The following is a description of a gene set: The chemical reactions and pathways resulting in the formation of carbohydrates, any of a group of organic compounds based of the general formula Cx(H2O)y. studied in species Mus musculus Mouse Gene Set: GOBP_CARBOHYDRATE_BIOSYNTHETIC_PROCESS, and this is the list of marker genes: Gys2, Has2, Gpd1 (glycerol-3-phosphate dehydrogenase 1 (soluble)), Gpi1, Irs2 (insulin receptor substrate 2), Nnmt, Sds, Pgm2, Adipoq (NCBI Gene Id 11450), Dyrk2, Egf, Prkaca, B3galt1, Mdh1, Lep, Mup11, Epm2a, Ppp1r3d, Chst8, Akt2, Lhcgr, Prkag2, Ext2, Mpdu1, Mup4, Ep300, Ppp1ca, Lalba, Ppp1r3c, Pgp, B3galt2, Gys1, Pck2, Dgkq, Ogt, Ins1, Tgfb1, Ppara, Akt1, Pth1r, Gyg1, Chst11, Atf4, Gpt2, Chst15, Prkag3, Parp1, G6pdx, Mtor, Supt20, St6galnac1, Slc37a4, Crtc2, Enpp1, B3gat2, C1qtnf3, Clk2, Has3, Pgam2, Zfp692, Abo, Myh9, Ddb1, Ppp4r3a (protein phosphatase 4 regulatory subunit 3A), Plek, Gcg, Mup1, C1qtnf12 (NCBI Gene Id 67389), Sirt1, Mas1, Mdh2, Gapdhrt, Aldoc, Ppp1r3e, Sord, Cry1, Foxo1, Mup2, Rgn (NCBI Gene Id 19733), Ptafr (NCBI Gene Id 636551), Pcx, Esrrb, Igf2, Mtcl2, Pdgfb, Ppp1cb, Ins2, Sirt7, Inpp5k, Ext1, Nfkb1, Il6, Car5a, Oprm1, Gapdhrt2, Epm2aip1, Pask (PAS domain containing serine/threonine kinase), Grb10, Ppp1r3b, Pfkfb1, Fbp1, Pgk2, Obp2a, Snca (NCBI Gene Id 20617), Sorbs1, Pgd, Slc25a13, Akr1b1, Ptpn2, Kat2a, Ugt1a6a, Xpc, Gbe1, Mup5, Mup3, Rbp4, Lepr, Gpt, Gper1, Igf1, C1qtnf2, Wdr5, Prkag1, Gpd2, Ntsr1, Ppp1r3f, Pgm1, P2ry1, Akr1a1, St8sia6, Gapdh, Nr1d1, Serpina12, Nr3c1, Hif1a, Chst12, G6pc1, Aldob, Mst1, Ugp2, Sirt6, Nans, Per2 (NCBI Gene Id 18627), Eno1, Gsk3b, Nln, Chst14, Sec1, Adcyap1r1, Atf3, St6galnac5, Ndst1, Got1, St6galnac6, Chst10, Irs1, Fbp2, Fut9, Mgat2, Fut2 (fucosyltransferase 2), Ranbp2, Prkg1, Ptges3, Gnmt, Dgat2, Arpp19, P2ry6, Slc25a10, Slc35b4, St3gal4, Gck, Stk11, Gsto1, Erfe, Sesn2, Acadm, Pgam1, B4galt1, Insr, Nhlrc1, Usp7, Gulo, Cyp2j6, Has1, Ap2a1, Pgk1, Pth, Pou1f1, Ptger4, Chst9, Pdk2, Ppargc1a, Ppp4r3b, Plcd1, Tpi1, Sik1, G6pc2, Cltc, Tcf7l2, B3galnt1, G6pc3, Eno2, Gnpda1, Hnf4a, G6pd2, Ppp1r3g, Smpd3, Gfpt1, St3gal2, Kat2b, Pck1, Slc25a11, Fut1, Ppp1r3a, Avpr1b, 1810024B03Rik, Slc39a14, Cd244a